The following is a description of a gene set: species: Mus musculus Mouse Gene Set: MIR_7068_5P from publication Chen Y, Wang X (PMID 31504780) Genes predicted to be targets of miRBase v22 microRNA mmu_miR_7068_5p in miRDB v6.0 with MirTarget v4 prediction scores > 80 (high confidence targets)., and this is the list of marker genes: Ccny, Slc4a5, Icam2, Efna1, Prol1, Magi2, BC048671, Serpinb1a, Acat2, Zfp292, Ccn2, Grk5, Rnf222, Dpysl3, Osbpl1a, Cldn12, Ppargc1a, Ly6e, Clta, Zeb2 (NCBI Gene Id 319891), Mbd6, Usp47, Vps13d, Ccdc81, Scaf11, Crot, Pcgf3 (NCBI Gene Id 69587), Trmt10a, Zfp397, Ogt, Iigp1, Nr2e1, Edn2, Copz1, Sox5, Hmmr, Satb1, Tmem217, Slc25a17, Ube2i, Caprin2